Given this list of marker genes Crkl, Arf6, Crk, Met, Rab4a, Gga3, Gab1, Hgf, Rab4b, Grb2, here is a description of the gene set: Mouse Gene Set: REACTOME_MET_RECEPTOR_RECYCLING studied in species Mus musculus MET receptor recycling